The following is a description of a gene set: Genes predicted to be targets of miRBase v22 microRNA mmu_miR_187_3p in miRDB v6.0 with MirTarget v4 prediction scores > 80 (high confidence targets). studied in species Mus musculus Mouse Gene Set: MIR_187_3P from publication Chen Y, Wang X (PMID 31504780), and this is the list of marker genes: Hnrnpll, Ctse, Smarce1, Brip1, Pxn, Fbxo33, Gpr12, Adamtsl3